The following is a description of a gene set: Each fraction of mouse hematopoietic cells was purified by cell sorting from bone marrow of 8-week-old C57BL/6 mice, and its gene expression was analyzed. Genes up-regulated in comparison of lineage negative versus B cells. Human Gene Set: GSE27786_LIN_NEG_VS_BCELL_UP from publication Konuma T, Nakamura S, Miyagi S, Negishi M, Chiba T, Oguro H, Yuan J, Mochizuki-Kashio M, Ichikawa H, Miyoshi H, Vidal M, Iwama A (PMID 21540074) species: Homo sapiens, and this is the list of marker genes: REPIN1, AP1AR, BHMT2, FDPS (NCBI Gene Id 2224), RABGGTB (Rab geranylgeranyltransferase subunit beta), FNIP2, TMEM106C, GLA, MMS22L, NENF, MYL1, WDR75, PIK3CD, CTSW, LDB1, METTL13, RIMKLA, DYNLL2, PLEKHA8 (pleckstrin homology domain containing A8), BMPR2, PAQR8, FIRRE, ABI2, FAM222A, ARL2, EPB41, PSMG2, OPTN, WDR62, CXCL13, ERI2, ACADSB, GZMB, FCER1G, HSPD1, PTPN20, PAFAH2, EIF2B4, PTPN14 (NCBI Gene Id 5784), RAD51AP1, KICS2, PTOV1, TBC1D4, SPATA7, SKA2, LCP2, PARD6G, SOX13, PRC1, SIGMAR1, HAPLN4, NUP43, CCT8, SCRN3, ADAMTS9, SGO2, SRRM1, GNG3, SLC35G6, TERT, ITPA (NCBI Gene Id 89313), BUB1B, UBE2N, SLC7A14, DPAGT1, SLC25A35, ASB9, TTLL12, PPA1, ZCCHC13, TMEM178A, ST7, ZHX3, SERPINA12, MLKL, SLC4A11, RBL1, ZNF239, CCDC102A, UBQLN4, MRPS35, SIX5, SLC14A1, FAM149A, JDP2 (Jun dimerization protein 2), MNS1, ADGRG5, DMKN, RNF4, DBI, ATP1A2, PTPN9, ACSL5, ADGRL2 (NCBI Gene Id 23266), LRP8, ALDH18A1, PCYT1A, SERPINE2, ECI2, ZBTB45, CCNF, CAD, GTSE1, CASP12, NCCRP1, DIAPH3, SLC43A3, AK3, ORC6, PXYLP1, WBP11, MTM1, MRS2 (magnesium transporter MRS2), RUVBL1, MOGS, CCDC34, PNP, PCM1, MRPL3, OBI1, OCSTAMP, SLC32A1, ABCB6 (NCBI Gene Id 541461), CYP24A1, CITED4, CALU, IL6ST (interleukin 6 cytokine family signal transducer), CLEC1B, GCSH, GSDME, METAP1D, LMNB2, AK4 (adenylate kinase 4), DCAF1, ETFDH, LRRC8C, KLK8, ELF3, G3BP1, UBE3B, GLRX, INAFM1, HK2, NPHS2, SLC25A24, DDX28, TM9SF4, KLHL12, TLNRD1, RPN2, SLC9A9 (NCBI Gene Id 339579), INTS1, UBR7, ATP10A, ALG2, ZNF771, ITK, BORA, EIF4B, DDX21, PWP1, STEAP3, CCDC181, RNF24, DYNLT2B (dynein light chain Tctex-type 2B), CD247, LANCL1, NUP155, FAM171A1, DEPDC1B, CFAP20, MGMT (O-6-methylguanine-DNA methyltransferase), TRMT6, RPRD1B, ANKH, BLOC1S5, HHIP, PDAP1, EXOSC5, GEMIN8, ACSL3, PCDHB12, MYCT1, ST3GAL4, SLC25A18, VAV3, TNKS, API5, MCM3, IDI1, PPP1R7, DCAF10, CFAP68, KRT28, TMEM69, GSTM4, SSR3, CD44, SLCO3A1, GID4